The following is a description of a gene set: studied in species Mus musculus Mouse Gene Set: GOBP_SYNAPTIC_VESICLE_CLUSTERING The process that results in grouping synaptic vesicles in presynaptic structures., and this is the list of marker genes: Pclo (NCBI Gene Id 26875), Nlgn2, Picalm, Snap91, Ctbp1, Pten, Cdh2, Magi2, Nlgn3, Syn3, Rab3a, Ctnnb1 (catenin beta 1), Syn2, Bcl2l1, Pcdh17, Nlgn1, Syn1, Syndig1, Bsn, Nrxn1